The following is a description of a gene set: Bilateral clubfoot deformity. studied in species Homo sapiens Human Gene Set: HP_BILATERAL_TALIPES_EQUINOVARUS Bilateral talipes equinovarus, and this is the list of marker genes: PI4KA, TRPM3, SATB2, GLB1, STX5, COL3A1, CNTNAP1, GDF5, EBP, SYT1, FANCL, CHD7, ZIC3, PLOD3, RBM10, MAN2C1, CTU2, BMPR1B, CCNQ, SLC26A2, CTNNA2, MYT1L, SOX9, GDAP1, ABHD16A, MFSD2A, PIEZO2, RSPO2, VANGL1, TWIST1, SYNE1, UBE2A, WBP4, SH3PXD2B (NCBI Gene Id 57517), PSAT1, PIGL, SLC35D1, CLCN3, PRUNE1, SNRPN, DHCR24, MAN2B1, GLDN, B3GALT6, MAPK1, YME1L1, PITX1, STAC3, DSE, RAB11B